The following is a description of a gene set: studied in species Mus musculus Mouse Gene Set: CUI_T_CELL_GD_NOGGIN_RESPONSE_DN Genes negatively differentially expressed in cell type: γδ T cell upon treatment with cytokine: Noggin in mouse lymph nodes in vivo. Cytokines mediate cell-cell communication in the immune system and represent important therapeutic targets. A myriad of studies have highlighted their central role in immune function, yet we lack a global view of the cellular responses of each immune cell type to each cytokine. To address this gap, the authors created the Immune Dictionary, a compendium of single-cell transcriptomic profiles of more than 17 immune cell types in response to each of 86 cytokines (>1,400 cytokine-cell type combinations) in mouse lymph nodes in vivo. A cytokine-centric view of the dictionary revealed that most cytokines induce highly cell-type-specific responses. For example, the inflammatory cytokine interleukin-1β induces distinct gene programmes in almost every cell type. A cell-type-centric view of the dictionary identified more than 66 cytokine-driven cellular polarization states across immune cell types, including previously uncharacterized states such as an interleukin-18-induced polyfunctional natural killer cell state. from publication Cui A, Huang T, Li S, Ma A, Pérez JL, Sander C, Keskin DB, Wu CJ, Fraenkel E, Hacohen N (PMID 38057668), and this is the list of marker genes: Emb, Btg2, Fos, Csrnp1, Stk17b, Jun (jun proto-oncogene), Jund, Fosb, Ier2, Klf6 (Kruppel-like transcription factor 6), Tnfaip3, Gadd45b, Nr4a1, Zfp36, Junb, Fosl2, Ppp1r15a, Uba52, Hspa1b, Ubc, Pnrc1, Dusp1, Rgs1